The following is a description of a gene set: The chemical reactions and pathways resulting in the breakdown of glutamate, the anion of 2-aminopentanedioic acid. Human Gene Set: GOBP_GLUTAMATE_CATABOLIC_PROCESS species: Homo sapiens, and this is the list of marker genes: GLUD2, ADHFE1, GLUD1, GAD2, GOT2, GOT1, GAD1 (glutamate decarboxylase 1), GLUL